Given this list of marker genes Cxcl2, Drd3, Trdmt1, Oxt, Drd4, Rgs10, Fosb, Drd2 (NCBI Gene Id 13489), Nr4a1, Edn1, Th, Grin2a, Hdac6, Hprt1, Rgs9, Dbh, Ppp1r9b, Comt, Ppp3ca, Grin1, Nr4a2, Ranbp2, Pde1b, Gnal, Asic1, Rgs2, Adra1b, Slc18a2, Adora2a, Drd1, Oxtr, Ednra, Ppp1r1b, Drd5, Slc1a1, here is a description of the gene set: Mouse Gene Set: GOBP_RESPONSE_TO_AMPHETAMINE Any process that results in a change in state or activity of a cell or an organism (in terms of movement, secretion, enzyme production, gene expression, etc.) as a result of an amphetamine stimulus. Amphetamines consist of a group of compounds related to alpha-methylphenethylamine. species: Mus musculus